Given this list of marker genes NEIL1, OGG1, NTHL1, NEIL3, MUTYH, here is a description of the gene set: species: Homo sapiens Diseases of Base Excision Repair Human Gene Set: REACTOME_DISEASES_OF_BASE_EXCISION_REPAIR